Given this list of marker genes TNKS1BP1, TEX12, HORMAD1, PDS5A (NCBI Gene Id 23244), HUS1, SMC3, H1-0, IHO1, BIRC5, HJURP, CENPF, PELO, SIRT1, CCSAP, MAP3K4, DCLRE1B, PRP4K, SHOC1, FLNA, KIF22 (NCBI Gene Id 728037), CENPX, DPF3, PINX1, CDCA5, UBE2C, PPP1R10, H1-2, HUS1B, BAG6, SKA3, MCMBP, DPF1 (double PHD fingers 1), PPP2R5C, MSH4 (mutS homolog 4), USP44, SMC1B, BOD1, SPO11, HMGB1, SKA1, CENPN, YY1, NASP, BCCIP, SEH1L, SMC1A, MSH2, NSMCE2, HNRNPA1, BAZ1B, KAT6A, PTTG3P, HMGA2, ANAPC2, PUM2, NSMCE4A, AURKC (NCBI Gene Id 6795), MYBL2, CHMP4C, CDT1, RUVBL2, STAG2, TAL1, DMC1, SIRT6, CDCA8, FANCD2, DOT1L, MAD2L2, SMARCD2, RAD51D, SYCE3, HECW2, BECN1, DRG1, H4C12, MOS, CHMP7, APC, NCAPD3, NCAPG, MAP3K20, C14orf39, RAB11A, LRRC34, RNF4, BANF2, KIF23, AURKB, ACTR5, KPNB1, RAD51C, CENPA, PRKDC, NSL1, TTN, PSMG2, SRC, GOLGA2, NBN, STN1, KNL1, DLGAP5, CLASP2, ANAPC11, APEX1, MAPKAPK5, RPA1, RTEL1, CCNE2, RECQL4, H4C4, MAD1L1, NAA10 (NCBI Gene Id 8260), CENPP, CHMP2A, RNF212 (ring finger protein 212), ZNF827, ARID2, MLH3, INO80, BRIP1, PRDM9, CHAMP1, DFFB, TFPT, SLX4, CENPW, CHMP1B, TERT, UHRF1, SENP6, LSM14A, SMARCC2, H1-4, SYCP1, ATR, H1-3, SHLD1, MSH5, MZT1, MAEL, ERN2, H3C2, MEI4, XRCC6, AGO4, CDC16, SMC6 (structural maintenance of chromosomes 6), STAG3, CDC23, USP7, TERF1, PRC1, BRD7, DIS3L2, ERCC4, MIS12, DDX11L8, SMC4, ACTL6A, ANAPC7, SHLD2, KNTC1, TERF2IP, EML4, SMARCA2, CHMP1A, NAA50, RAD21, CCT5, PARP1, NUSAP1, H3C12, KIF18A, ZNF830, NUP98, NVL, H4C16 (NCBI Gene Id 121504), SPATA22, CCT2, TFIP11, GAR1, CDK5RAP2, XRCC1, KIF14, TOP2B, ANAPC15, HNRNPA2B1, CHMP4BP1, ATRX, ARHGEF10, PRM2, BANF1, MAP9, KNSTRN, POLDIP2, ITGB3BP, H3C11, TENT4A, NHP2, ZWINT, ITPA, RAD51 (NCBI Gene Id 5888), SETMAR, BCL7B, H1-10, PML, PTTG2, TCF7L2, DUSP1, H3C8, SLF1, TEX15, RIOK2, TOP2A, STAG1, CHFR, MRE11, NFRKB, SHLD3, ZWILCH, TPX2 (TPX2 microtubule nucleation factor), KIFC1, GTF2B (NCBI Gene Id 2959), HSP90AB1, NUP133, WRAP73, ESCO1, SLX1A, KIF4A, RAN, SPDYA, POGZ, NPR2, MAPK15, KIF2C, TNKS, GNL3L, RNF212B, NUP155, SYCP2, H2BC1, CHTF8 (NCBI Gene Id 54921), KLHL22, H1-1, ZBTB48, NIPBL, GEM, PBRM1, H3C3, NUMA1, SHCBP1L, RAD54L, MEIOC, TOP1MT, ERCC3, ABL1, RMI2, CEP97, FBXO4, ARID1A, GEN1, RHOA, H1-5, DNA2, SUGT1, MAJIN, SMARCA5 (NCBI Gene Id 8467), DCLRE1C, ANKRD53, PPP1CC, H3C1, HNRNPC, OFD1, RANGRF, TRIP13, DPF2, P3H4, NAF1, FEN1, CDK1, TERC, TERB2, PSMC3IP, NCAPD2, CENPC, UBE2B, SFPQ (NCBI Gene Id 6421), CCNB1IP1, RAD21L1, SYCE2, KAT5, TNKS2, KATNB1, KLF4, VPS4A, LIG4, SPDL1, TOP1, CEP55, MAPK3, FSHR, PCNA, ZSCAN4, H4C5, SMARCC1, HNRNPD, MAP2K7, TPR, INO80D, ERCC1, HASPIN, NDC1 (NCBI Gene Id 55706), ARID1B, NEK7, ACIN1, CENPV (NCBI Gene Id 201161), XRCC3, TOP3A, SMARCB1, TDRD3, PIBF1, MSH3, KIF4B, H4C13, NOP10, ZMPSTE24, NABP2, HMGB2, RPA3, EID3, CHMP2B, RB1, ACD, SPC25, ZNF365, NDC80, HMGB3, TOPBP1 (DNA topoisomerase II binding protein 1), CTNNB1, XRN1, RAE1, SMARCE1, EXOSC10, SMC2, CHMP4A, MIS18A, DDX11, CENPH, PPP1CA, RCC1, HDAC8, CCT6A, MAP10, MEIKIN, NCAPG2 (non-SMC condensin II complex subunit G2), ABRAXAS1, RIF1, CCNB1, HSPA1B, WAPL, REC8, TEP1, SMCHD1, MISP, KIF3B, PCID2, MCMDC2, CHMP4B, RACGAP1, NEK2, XPA, BUB3, TEX14, CDC6, WRAP53, MTERF1, ANAPC1, SUN1, ANKRD31, DYNC1LI1, H3-3A, PHF10, TACC3, CCT3, H3-3B, RRS1, MAD2L1BP, CENPK, RUVBL1, BUB1B, PTGES3, TTK, INO80E, PPP2R5D, NPPC, HMBOX1, KIF18B, ESCO2, NUP107, HSPA1A, AAAS, PNKP, SMARCA4, H3C7, DDX12P, MAPK1, RMDN1, BCL7C, TEN1, EML3, HHEX, ABRAXAS2, CDK2, SPC24, LDB1, PHB2, SGO1, H4C15, TUBG1, TCP1, MCPH1, UCHL5, LMNA, PHF13, HSPA2, LATS1, HNRNPU, ACTL6B, FBXO30, VPS4B, BCL7A, CCT8, DSCC1 (DNA replication and sister chromatid cohesion 1), ZNF207, ATM, H4C6, SMG5 (NCBI Gene Id 23381), EXO1, MAD2L1, PARP3, PKIB, SLX1B, PRICKLE1, SMARCD1, TENT4B, C1orf146, TERF2, CENPT, ANAPC5, KIF15, RPA2, PARN, HAT1, PSRC1, CEP192, H4C3, FBXW7, ESPL1, NSMCE1, UPF1, EHMT2, CCDC66, OIP5, IK, KMT5A, EME2, MACROH2A1, AKAP8, CTC1, CENPE, H4C9, MCRS1, ZW10, H1-9P, POT1, XRCC5, DHX36, SYCE1, CDC27, RFC1, NUDC, TP53, CCT4, CDC20, NUP62, KASH5, INCENP, NAT10, CHMP5, CHEK2, SMC5, PRM1, CCT7, MAPRE1, KIF25, PLK1, PIF1, AKAP8L, YLPM1, LCMT1, PPP2R1A, PDCD6IP, RIPOR2, H3C10, BUB1, SYCE1L, PRAP1, TUBG2, PRKCQ, CTCF (NCBI Gene Id 10664), MAU2, NCAPH2, CLASP1, CHMP3, DKC1, MYC, RAD50, SP100, NCAPH, DCTN2, H4C8, TRAPPC12 (NCBI Gene Id 51112), H4C1, H1-6, WRN, MSH6, SMARCAL1, INO80C (NCBI Gene Id 125476), CENPI, SMARCD3, FBXO5, MND1, H4C11, MEIOB, TERB1, NEK6, ANAPC4, CCNE1, MLH1, KIF11, CENPO, TEX11, H1-8, AXIN2, H1-7, GPER1, SPAG5, PRM3, KIF2A, H4C2, PTTG1, NSMCE3, ACTR8, ZCWPW1, CCDC61, H3C4, ACTB, CUL3, KAT2B (NCBI Gene Id 8850), SPICE1, INO80B, GNL3, H3C6, TINF2, H4C14, HORMAD2 (HORMA domain containing 2), NHEJ1, SMG6, DCP2, MAPT, HSP90AA1, CIP2A, SIRT7, PPP2R1B, NUF2, LTO1, SLF2, TOP3B, SKA2, SMG1, BRCA2, H2BW1, SGO2, PDS5B, BLM (BLM RecQ like helicase), CHMP6, here is a description of the gene set: A process that is carried out at the cellular level that results in the assembly, arrangement of constituent parts, or disassembly of chromosomes, structures composed of a very long molecule of DNA and associated proteins that carries hereditary information. This term covers covalent modifications at the molecular level as well as spatial relationships among the major components of a chromosome. Human Gene Set: GOBP_CHROMOSOME_ORGANIZATION species: Homo sapiens